The following is a description of a gene set: Sparse eyelashes Decreased density/number of eyelashes. studied in species Homo sapiens Human Gene Set: HP_SPARSE_EYELASHES, and this is the list of marker genes: ITGA3, KRT71, CDH3, ALX4, EDAR, COL11A1, DPH1, POLR3A, NF1, MBTPS2, SOX18, CLDN1, KREMEN1 (NCBI Gene Id 83999), KRT74, KANK2, NOP10, LSS, CHD6, DOLK, IRX5, SF3B4, ST14, RPL21, KRT25, ODC1, EDA, DSC3, LIPH, TYMS, SNRPE, LTV1, EDNRA, NECTIN4, ZMPSTE24, HRURF, VAC14, FIG4, MPLKIP, APCDD1, CWC27, DSP, B4GALT7, DKC1, ALX1, SPINK5, NHP2, DSG4, RNU4ATAC, DLX4, CST6, EDARADD, LPAR6, FAM111B, TP63, BANF1 (barrier to autointegration nuclear assembly factor 1), NECTIN1, DPH5, TSR2, WDR35, ANTXR1, RMRP, TWIST2, PUM1, RECQL4, RNU12, SMARCA2, GJB6, GJB2, EPS8L3, EBP, MAP2K2 (NCBI Gene Id 85511), BLM, GJA1, GTPBP2, TCOF1, TRPS1